The following is a description of a gene set: Salmonella SopE/E2 to NOD-NFKB signaling pathway. Pathway ID: N01112. Pathway type: Pathogen. Pathway class: nt06521 NLR signaling. species: Homo sapiens Pathway Definition from KEGG: SopE/E2 -> CDC42 -> NOD1 -> RIPK2 -> IKK -> NFKBIA -> NFKB Human Gene Set: KEGG_MEDICUS_PATHOGEN_SALMONELLA_SOPE_E2_TO_NOD_NFKB_SIGNALING_PATHWAY, and this is the list of marker genes: CDC42, IKBKB, IKBKG, NOD1, RIPK2, CHUK, NFKB1, NFKBIA, RELA